The following is a description of a gene set: studied in species Mus musculus The chemical reactions and pathways resulting in the breakdown of any ribonucleoside, a nucleoside in which purine or pyrimidine base is linked to a ribose (beta-D-ribofuranose) molecule. Mouse Gene Set: GOBP_RIBONUCLEOSIDE_CATABOLIC_PROCESS, and this is the list of marker genes: Upp1, Xdh, Adal, Pnp2, Upp2, Urah, Pycr3, Cda, Ada, Ahcy, Pnp, Urad, Aicda, Uox, Enpp4, Cdadc1, Dctd, Ahcyl (adenosylhomocysteinase like)